Given this list of marker genes F2r, Pdgfb, Ttr, Gas6, Adora1, Coro2b, Uts2r, Gja5, Gja1, Ptpro, F2rl1, Uts2, Nr3c2, Cyba, Emp2, Cyp11b2, Hsd11b2, here is a description of the gene set: A slow mechanism of blood pressure regulation that responds to changes in pressure resulting from fluid and salt intake by modulating the quantity of blood in the circulatory system. Mouse Gene Set: GOBP_RENAL_SYSTEM_PROCESS_INVOLVED_IN_REGULATION_OF_BLOOD_VOLUME species: Mus musculus